Given this list of marker genes STK39, PRKCE, CAMK2D, MIR24-1, MIR448, NEDD4L, GRP, MIR192, COMMD1, PCSK9, AGT, OSR1, here is a description of the gene set: Any process that stops, prevents or reduces the frequency, rate or extent of sodium ion transmembrane transport. species: Homo sapiens Human Gene Set: GOBP_NEGATIVE_REGULATION_OF_SODIUM_ION_TRANSMEMBRANE_TRANSPORT